Given this list of marker genes BCL7A, HLA-DQB2, SUPT16H, SLC25A42, RANBP10, ZNF275, AMIGO1, HOOK3 (NCBI Gene Id 84376), XIRP1, GLP2R, HAX1, MTSS1, PPP1R1B, IRS1, LRFN2, DCN, CD2 (CD2 molecule), ANTXR2, PTPN23, LMOD1, STK38, DDR1, WDR82, SLC41A2, LYRM4, CASTOR2, EPHA8, CTDSP1, NTRK2, LENEP, EDAR, DDX17, CACNA1E, THOC7, DBH (NCBI Gene Id 1621), GUCA2B, ZBTB4, CISD1, PRR14L, GEM, LRTOMT, JPH4, GAPVD1, PELI3, LSM12, CYB5R3, KCTD15, RAB1B, ATG2A, TSPAN3, PDIA6 (NCBI Gene Id 10130), TMEM11, ELAPOR2, PARVA, PITPNM2, PTPRN, TNN, AGO1, ZFHX2, ALPK3, PAPPA2, MLEC, AIG1, PRX, MOCS1, COTL1, RBM43, NREP, PCDHB9, KIF17, MYOCD, YWHAH, TCOF1, MRAS, STMN2, LHX8, ENOSF1, BDNF, NFATC3, MGLL, SLC6A17, HLA-G, DLK1, GNAS, SNRPD3, MEF2D, CPLX4, SLC6A8, TMEM178B, TGM2, DIRAS1, ZGPAT, TSPAN9, RAB11FIP1, NOVA2, CABP2, ITM2C, RPTOR, SMG5 (NCBI Gene Id 23381), here is a description of the gene set: Human Gene Set: MIR541_3P Genes predicted to be targets of miRBase v22 microRNA hsa-miR-541-3p in miRDB v6.0 with MirTarget v4 prediction scores > 80 (high confidence targets). from publication Chen Y, Wang X (PMID 31504780) species: Homo sapiens